Given this list of marker genes Mthfd1l, Mthfr, Aldh1l1, Shmt2, Mthfsl, Mthfd2, Dmgdh, Shmt1, Tyms, Sardh, Mthfs, Ftcd, Mthfd2l, Dhfr, Mthfd1 (NCBI Gene Id 17767), here is a description of the gene set: species: Mus musculus The chemical reactions and pathways by which one-carbon (C1) units are transferred between tetrahydrofolate molecules, to synthesize other tetrahydrofolate molecules. Mouse Gene Set: GOBP_TETRAHYDROFOLATE_INTERCONVERSION